Given this list of marker genes DDX59, MED12L, WDR35, PUF60, CAPN15, SMC1A, SMS, ANAPC7, MID2, HOXB1, HEATR3, GPC4, here is a description of the gene set: Unilateral ptosis A unilateral form of ptosis. Human Gene Set: HP_UNILATERAL_PTOSIS species: Homo sapiens